Given this list of marker genes TAF12, TSHZ1, AUNIP, CSGALNACT2, TNFRSF1B, PDCD10, PGC, CCL4, TMF1, PI4K2B, IPO5, RDX, CYP2C18 (NCBI Gene Id 1562), BRME1, PAK6, S100A14 (NCBI Gene Id 57402), MTMR9, TRAPPC2, SGCB, GTSF1, ADAM22, GPR171, GAREM2, HNRNPDL, NDUFV2 (NCBI Gene Id 4729), RRAD, CENPL, ADAM17, GREB1L, SIRT1 (sirtuin 1), MXD1, PPP1R2P1, TARS1 (NCBI Gene Id 94887), SLA2, MRPL27, RALA, IL12RB2 (NCBI Gene Id 3595), ALG5, B3GAT3, CDC45, RTF1 (NCBI Gene Id 23168), ERI2, CD99, MRPL18, PHF13, CA5B, UMPS, FBXO30, UBE2L6, RNF166, HSPA5, SERINC3, SYT4, GTF2F2, ENO1, CACNB4, MMP12, PSMD1, WEE1, PACC1, CCNF, PEF1, SNRPC, LYAR, RBBP8, HDGF, SEPHS2, RPS6KA5, ETHE1, FAXC, SLC52A3, ARL5B, SEPTIN1, WBP2, S100A6, FIRRM, GNPTG, RHOF, EXO1, SPATA6, NIBAN1, GAS6, IRF8, SMARCC2, STIL, YWHAH (tyrosine 3-monooxygenase/tryptophan 5-monooxygenase activation protein eta), FBXO31, LMNB1, FAM185A, FAM111A (NCBI Gene Id 63901), PPM1G, CDV3, OTULIN, MTMR2, CSE1L, MPND (MPN domain containing), NCOA3, CCNE1, LSM11 (LSM11, U7 small nuclear RNA associated), CDR2, TFAP2E, CEP44, LIN7A, AHCYL1, RORC, MYL6, NAALADL1, COPS3, DIAPH3, SAPCD1, LAMB3, CENPJ, TKT, ZNF606, MED21, LYSMD3, CARHSP1, ANXA7 (annexin A7), BUB1, CASP7, STX12, NEUROG3, PDP1, CCT6A, KIF22, APOBR, NR5A2, PSPH, NSMCE2, CTNNBIP1, CSNK2B, CYTH4, GABARAPL2, SAP30, HADH, GRAMD2B (GRAM domain containing 2B), BICD2, MLKL, PPP1R12A, TPPP3, CDC34, MED11, SPPL3, TICRR, KPNA3, TMCC3, MTDH, UXS1, H2AX, GLRX, LGALS1, TAFA3, TNFSF10, CDCA2, BRIP1, EIF4E3, SPC24 (SPC24 component of NDC80 kinetochore complex), ARID3B, ATAD5, SMC5, CDC14B, C2orf68, SPAG5, SNX9, RIT2, KNL1, KCNJ8, DNAJB1, AIRN, RAD21, TNFSF9, ANKRD11, TRAPPC8, ANKLE1, HNRNPAB, SLC4A3, P3H4, RARS1, ACAA2, ELOF1, MOSMO, EIF2B5, CHSY1, ZMIZ1 (NCBI Gene Id 57178), HAUS3, CPOX, KIF20B, POLD3, ERCC6L, ITGB3, SCYL2, KPNA2, CCND2, NDEL1, SELENOI, DLD, TUBB3, TRAPPC6B, CRELD2, here is a description of the gene set: Genes down-regulated in CD4 T cells: IL1B, IL6 and IL-23 versus IL1B, IL6 and TGFB1. species: Homo sapiens CD4+ T cells that selectively produce interleukin (IL)-17, are critical for host defense and autoimmunity1-4. Crucial for T helper17 (Th17) cells in vivo5,6, IL-23 has been thought to be incapable of driving initial differentiation. Rather, IL-6 and transforming growth factor (TGF)-β1 have been argued to be the factors responsible for initiating specification7-10. Herein, we show that Th17 differentiation occurs in the absence of TGF-β signaling. Neither IL-6 nor IL-23 alone efficiently generated Th17 cells; however, these cytokines in combination with IL-1β effectively induced IL-17 production in naïve precursors, independently of TGF-β. Epigenetic modification of the Il17a/Il17f and Rorc promoters proceeded without TGF-β1, allowing the generation of cells that co-expressed Rorγt and T-bet. T-bet+Rorγt+ Th17 cells are generated in vivo during experimental allergic encephalomyelitis (EAE), and adoptively transferred Th17 cells generated with IL-23 in the absence of TGF-β1 were more pathogenic in this experimental disease. These data suggest a new model for Th17 differentiation. Consistent with genetic data linking the IL23R with autoimmunity, our findings re-emphasize the role of IL-23 and therefore have important implications for the development of new therapies. from publication Ghoreschi K, Laurence A, Yang XP, Tato CM, McGeachy MJ, Konkel JE, Ramos HL, Wei L, Davidson TS, Bouladoux N, Grainger JR, Chen Q, Kanno Y, Watford WT, Sun HW, Eberl G, Shevach EM, Belkaid Y, Cua DJ, Chen W, O'Shea JJ (PMID 20962846) Human Gene Set: GSE23505_IL6_IL1_IL23_VS_IL6_IL1_TGFB_TREATED_CD4_TCELL_DN